Given this list of marker genes FBXO32, HERC1, STK17B, ATM (NCBI Gene Id 8068), HCG27, GPR68, ITGA6, STAG3L1, BMAL1, AQP3, PCED1A, PIK3IP1, RASA3, SUN2, MED13L, PBX4, TSC1, EDAR, ENTPD4, BTN3A1, HSBP1L1, AKAP13, GLIPR1, ANKRD36B, VPS13C, ATXN7L1, VNN2, CCNG2, PRRC2B, SAP30L, KLF3, APOL3, SYNE2, BBIP1, FAM223B, ZBTB18, ZSCAN2, MICAL1, KANSL1, GRAP, ARL4C, HERPUD2, APBA2, HBP1, FGD3, P2RY8, ATG14, ZCCHC14, LYRM9, PELI2, SLC25A25-AS1, ZFYVE1, LINC00528, ZNF394, WHAMM, RASGRP1 (NCBI Gene Id 10125), BCL11B, TLE4, FBXL20, OCEL1, KLRB1, MARCHF8, YPEL4, H2AC6, NLRP1, POGZ, MPPE1, MAL, TC2N, NLRC3, CD52, ZNF862, EPHA4, ACSS1, LEPROTL1, TANC2, ARHGEF18, POU6F1, IL7R, SPSB3, PRKCQ, CHKB, GSN, MALAT1, IDS, SENP7, DENND6A, PDCD4, PNRC1, RASSF6, PBXIP1, CNOT6L, ARHGAP45, NLRC5, ZFP36L2, PDK3, SPOCK2, LINC01138, YPEL2, TNRC6B, FCMR, NDRG1, DDX6, TRIM73, GAL3ST4, GZMK, ABLIM1, CREBRF, GSTK1, UTRN, C16orf54, HECTD4, TRPV1, RALGPS2, SLC35D2, ST3GAL5, TSC22D1, IL10RA, IRAG2 (inositol 1,4,5-triphosphate receptor associated 2), LAPTM5, SH3BP5-AS1, RIPOR2, NKTR, OFD1, AK1, PAN3, PECAM1, CYTH1, RNF166, MLXIP, ADA2, PPP3CA, SERINC5, YPEL5, HACD4, FRAT1, SETD1B, PDCD4-AS1, ANXA2R-AS1, TPBG, SSH2, VAMP1, KLF2, RTL10, ATXN7, PHF21A, SNN, RNF103, LINC02481, SCML4, ITFG2, ZBTB20, TXNDC16, CAPRIN2, GSAP, SPDYE1, ADD3, GOLGB1, AGO4, ATF7IP2, TSC22D3, ACCS, IFNAR2, SLC9A9, ARRDC2, USP3, RABGAP1L, NF1, FOXO3, CSNK1G2, DPEP2, MIR497HG, PIAS1, IFFO1, CRTC3, CCDC18-AS1, CXCR4, PIK3R5, SYTL2, NR1D2, MBP (NCBI Gene Id 4155), TECPR1, ZBTB40, SORL1, ABTB3, B3GALT4, GPR18, EEIG1 (NCBI Gene Id 90676), IPCEF1, ARHGDIB, PIK3R1, NUDT7, PINK1, MAP3K1, SCML1, here is a description of the gene set: Human Gene Set: GSE16450_IMMATURE_VS_MATURE_NEURON_CELL_LINE_UP species: Homo sapiens from publication Peltier DC, Simms A, Farmer JR, Miller DJ (PMID 20483728) Genes up-regulated in the neuron cell line: immature versus mature. Human neuronal differentiation alters responsiveness to innate immune stimuli and virus infections. We used microarrays to examine the transcriptional responses of the human BE(2)-C neuroblastoma cell line to retinoic acid-induced differentiation and type I IFN stimulation.